Given this list of marker genes RIN3, DNM1, RAB3B, BLOC1S2, BORCS6, BORCS5, BORCS7, RAB22A, CHMP3, BLOC1S1, RAB5A, ALS2, WASHC5, KXD1, SNAPIN, BORCS8, PICALM, AP2M1, here is a description of the gene set: studied in species Homo sapiens Human Gene Set: GOBP_REGULATION_OF_VESICLE_SIZE Any process that modulates the size of a vesicle.